The following is a description of a gene set: Mouse Gene Set: GOBP_POSITIVE_REGULATION_OF_MULTICELLULAR_ORGANISM_GROWTH Any process that activates or increases the frequency, rate or extent of growth of an organism to reach its usual body size. studied in species Mus musculus, and this is the list of marker genes: Bbs4, Stat5b, Gh, Sgip1, Ghr, Ghrh, Ezr, Hmga2, Nipbl, Drd2, Ghrhr, Vil1, Mkks, Celf1, Sh3pxd2b, Dlg1, Ppib, Smo, Flt3, Pls1, Csf1, Hsf1, Tshr, Sptbn4, Pou1f1, Gpam, Creb1, Ikzf1, Pou3f2, Slc6a3, Igf2, Bcl2, Gpr21, Dio3, Stat5a, Pex5, Ghsr, Foxs1, Chd7, Atp8a2, Bbs2, Agt